The following is a description of a gene set: Mouse Gene Set: GOBP_L_PROLINE_TRANSMEMBRANE_TRANSPORT studied in species Mus musculus The directed movement of L-proline across a membrane., and this is the list of marker genes: Slc6a20b (solute carrier family 6 (neurotransmitter transporter), member 20B), Slc38a2, Slc6a20a, Ace2, Cltrn